Given this list of marker genes ID1, RPL34P1, NTF3, SMAD7, PHF3, HAS2, TNFAIP3, EIF4E, NRIP1, ID2, BACH1, SNX4, KIF2A (NCBI Gene Id 3796), MAP1B, ZNF217, RAPGEF2, EDRF1 (NCBI Gene Id 80200), THBS1, NUP153, SECISBP2L, ZBED4, MTMR3, RYBP, DUSP5, RUNX1, PCGF3 (polycomb group ring finger 3), AUTS2, N4BP1, MAT2A, PNN, GAS1, SATB2, CENPA, CHD1 (NCBI Gene Id 1105), NFE2L2, ZC3H4, BDNF, GTF2E1, here is a description of the gene set: from publication Gentile M, Latonen L, Laiho M (PMID 12907719) Human Gene Set: GENTILE_UV_RESPONSE_CLUSTER_D2 DNA damage caused by UV radiation initiates cellular recovery mechanisms, which involve activation of DNA damage response pathways, cell cycle arrest and apoptosis. To assess cellular transcriptional responses to UVC-induced DNA damage we compared time course responses of human skin fibroblasts to low and high doses of UVC radiation known to induce a transient cellular replicative arrest or apoptosis, respectively. UVC radiation elicited >3-fold changes in 460 out of 12,000 transcripts and 89% of these represented downregulated transcripts. Only 5% of the regulated genes were common to both low and high doses of radiation. Cells inflicted with a low dose of UVC exhibited transcription profiles demonstrating transient regulation followed by recovery, whereas the responses were persistent after the high dose. A detailed clustering analysis and functional classification of the targets implied regulation of biologically divergent responses and suggested involvement of transcriptional and translational machinery, inflammatory, anti-proliferative and anti-angiogenic responses. The data support the notion that UVC radiation induces prominent, dose-dependent downregulation of transcription. However, the data strongly suggest that transcriptional repression is also target gene selective. Furthermore, the results demonstrate that dose-dependent induction of cell cycle arrest and apoptosis by UVC radiation are transcriptionally highly distinct responses. Cluster d2: genes down-regulated consistently in WS1 cells (fibroblast) between 6 h and 24 h after irradiation with high dose UV-C. studied in species Homo sapiens